The following is a description of a gene set: Human Gene Set: GOMF_K63_LINKED_POLYUBIQUITIN_MODIFICATION_DEPENDENT_PROTEIN_BINDING Binding to a protein upon poly-ubiquitination formed by linkages between lysine residues at position 63 in the target protein. species: Homo sapiens, and this is the list of marker genes: SQSTM1, WDR81 (WD repeat domain 81), ZRANB3, RNF169, IKBKG, MINDY2, OTUD7A, SPRTN, ASCC2, UIMC1, FAAP20, PRPF8, IKBKE, PARP10, ZBTB1, RNF168, TAB2, RNF31, ATRIP, OPTN, TNFAIP3, TAB3, OTUD7B, ZRANB1, NPLOC4, TNIP2